Given this list of marker genes JAK2, RFXANK, IL4, SLC11A1, IFNG (interferon gamma), PF4, SIRT1, IL33, TLR4 (toll like receptor 4), TMEM106A, AZU1, IL10, CIITA, SPI1, RFX5, XBP1, TAF7, NFX1, CDK5R1, RFXAP, here is a description of the gene set: Human Gene Set: GOBP_MHC_CLASS_II_BIOSYNTHETIC_PROCESS species: Homo sapiens The chemical reactions and pathways resulting in the formation of major histocompatibility protein class II.